Given this list of marker genes Rdh12, Esd, Sgk1 (serum/glucocorticoid regulated kinase 1), Aldh1a1, Scnn1a, Ace, Rdh11, Nr3c2, Aldh1a7, Scnn1g, Akr1a1, Aldh2, Scnn1b, Adh4, Akr1b1, Aifm1, Tgfb1, Adh5, Park7, here is a description of the gene set: Any process that results in a change in state or activity of a cell (in terms of movement, secretion, enzyme production, gene expression, etc.) as a result of an aldehyde stimulus. studied in species Mus musculus Mouse Gene Set: GOBP_CELLULAR_RESPONSE_TO_ALDEHYDE